Given this list of marker genes NAF1, CCR6, SLC7A7, POLR3H (NCBI Gene Id 91605), TINF2, NUP107, BACH2, CTLA4, MARS1, ZSWIM7, NHP2 (NCBI Gene Id 55651), NPC2, NHLRC2, SFTPA2, IRF5, RAC2 (NCBI Gene Id 5880), HPS4, GATM, MUC5B, STING1, TERC, SFTPC, TERT, MSH4, STN1, KIAA0319L, NDUFAF6, TOM1, BTNL2, EHHADH, HLA-DRB1, ABCA3, SLC34A1, SFTPA1, RCBTB1, CAV1, BNC1, THOC2, SLC34A2, IL1RN, HLA-B, ZCCHC8, FSHR (follicle stimulating hormone receptor), SPIDR, CCN2, DSP, NKX2-1, PTPN22, AP3B1, GBA1, NOP10, NR5A1, PRTN3, HPS6, PLEC, MRPS22, FASLG, HLA-DPB1, PARN, FAM111B, ATP11A, CASP10, BMP15, CYBC1 (cytochrome b-245 chaperone 1), DPP9 (dipeptidyl peptidase 9), DKC1, POT1, RNF168, TP53, SP110, PSMC3IP, RPA1, CTC1, FAS, RTEL1, HPS1, FAM13A, HLA-DPA1, here is a description of the gene set: Replacement of normal lung tissues by fibroblasts and collagen. Pulmonary fibrosis Human Gene Set: HP_PULMONARY_FIBROSIS studied in species Homo sapiens